Given this list of marker genes Smc5 (NCBI Gene Id 265456), Wrn, Clspn (NCBI Gene Id 97173), Ercc5, Neil3, Rad51b, Msh2, Rad51ap1, Rad18, Hmgb1, Xrcc3, Xrcc2, Men1, Hmgb3, Hmga1b, Fancm, H1f0, Rad51c, Smc6, Mecp2, Pou3f4, Recql4, Abl1, Hnrnpd, Hmga2, Tcf20, Gen1, Pax6, Pot1b, Lin54, Hmga1, Rad51d (RAD51 paralog D), Hand2, Nr0b1, Mef2c, Pot1a, Msh6, Blm, Hmg20b, Yy1, here is a description of the gene set: Mouse Gene Set: GOMF_DNA_SECONDARY_STRUCTURE_BINDING Binding to a DNA secondary structure element such as a four-way junction, a bubble, a loop, Y-form DNA, or a double-strand/single-strand junction. studied in species Mus musculus